The following is a description of a gene set: Cytokines mediate cell-cell communication in the immune system and represent important therapeutic targets. A myriad of studies have highlighted their central role in immune function, yet we lack a global view of the cellular responses of each immune cell type to each cytokine. To address this gap, the authors created the Immune Dictionary, a compendium of single-cell transcriptomic profiles of more than 17 immune cell types in response to each of 86 cytokines (>1,400 cytokine-cell type combinations) in mouse lymph nodes in vivo. A cytokine-centric view of the dictionary revealed that most cytokines induce highly cell-type-specific responses. For example, the inflammatory cytokine interleukin-1β induces distinct gene programmes in almost every cell type. A cell-type-centric view of the dictionary identified more than 66 cytokine-driven cellular polarization states across immune cell types, including previously uncharacterized states such as an interleukin-18-induced polyfunctional natural killer cell state. from publication Cui A, Huang T, Li S, Ma A, Pérez JL, Sander C, Keskin DB, Wu CJ, Fraenkel E, Hacohen N (PMID 38057668) species: Mus musculus Mouse Gene Set: CUI_T_CELL_CD8_IFNB_RESPONSE_UP Genes positively differentially expressed in cell type: CD8+ T cell upon treatment with cytokine: IFN-β in mouse lymph nodes in vivo., and this is the list of marker genes: Ifi213 (NCBI Gene Id 623121), H2-D1, Tmem184b, Herc6, Mitd1, Ifit1bl1, Cpne3, Nlrc5, Smchd1, Uba7, Laptm4a, Plac8, Ms4a6b, Taldo1, Ifi27l2a, Plgrkt, Ms4a6d, Trim25, Ankfy1, Ncl, Tasor2, Trim26, Ifit1, Cnot6l, Icam1, Phip, Nsd3, Il2rg, Vars1, Asb13, Max, Psma3, Lgals9, Ifi208, H2-Q4, Usp18, Lgals8, Aida (axin interactor, dorsalization associated), Ubald2, Tmem192, Gpr18, Mrpl30, Tor3a, Cars1, Slamf7, Stat1, Hk1, Zcchc2, Epsti1, Rgs1, Myd88, Ifi204, Ms4a4b, Trim30d, Bbx, Cd274, Apobec3, Hspa5, Gbp6, Pdcd10, Cmpk2, Isg20, 9930111J21Rik2, Tut4, Clic4, Art2b, Dhx58, Irf2, Slfn1, Ezr, Pdlim2, Sell, Arl6ip1, Lsm4, Bst2, Phgdh, Fchsd2, Cxcl10, Parp14, Tgtp1, Rtp4, Ppp6r1, Etnk1, Jaml, Svbp, Pttg1, Ptma, Keap1, Socs1, Rbck1, Rnf213, Tap2, Mthfd2, Oas1a, Gbp3, Mndal, Tlr7, Sp110, Gbp5, Sp100, Ppa1, Zup1 (zinc finger containing ubiquitin peptidase 1), Med28, Psma4, Ranbp1, Pim1, Oas2, Setdb2, Usp25, Pnpt1, Dtx3l, Clec2d, Plaat3, Shisa5, Ifitm3, Tmem243, Psmb10 (NCBI Gene Id 19171), Ms4a4c, H2-K1, B4galt5, Trim12c, Nup210, Irf8, Atp8a2, Larp1, Calhm6 (NCBI Gene Id 215900), Adar, Fam241a, Tapbp, Psmb8, Hsh2d, Ddx24, Isg15, Slfn8, H2-T23, Snx2, Tapbpl, Tcstv4, Psme1, Sdc3, Shmt2, Helz2, Ddx39b, Phc2, Rbm43, Eomes, Irf9, Igfbp4 (insulin-like growth factor binding protein 4), Slfn2, Psme2, Ifi203, Xaf1, Gadd45g, Ogfr, Selenow (selenoprotein W), Parp12, Cycs (NCBI Gene Id 13063), B2m, Prrc2c, Gzma, Rabepk, Parp9, Slfn5, Tnfsf10, Lgals3bp, Znfx1, Ilrun, Stat2, Gbp4, Ube2l3, Cd2 (CD2 antigen), Ly6e (NCBI Gene Id 17069), Cd47, BC051226, Zbp1, Phf11a, Psma5, Eif2ak2, Eif2s2, Gbp8, Pdia3, Ly6c2, Ly6a, Ccnd2, Mov10, Treml2, Iigp1, Trafd1, Gbp9, Map2k1, Tap1, Ctss, Irf7, Chmp4b, Casp8 (caspase 8), Dpp4, Vcpip1, H2-Q7, Phf11b, Acadl, Trim21, Aldoa, Irgm2, Tbrg1, Morc3, Nars1, Samd9l, Pml, Psmb9, Atp8b4, Gtpbp2 (GTP binding protein 2), Fnbp4, H2-T22 (histocompatibility 2, T region locus 22), Nampt, Oasl2, Desi2, Ifi206, Fam111a, Parp10, Trim30c, Cnp, Gbp2, Ncoa7, Capza2, Ifit3, Rsad2, Srsf3, Tcof1, Cd86, Rigi, Irgm1, Cytip, Itpr1, Psma7, Itm2b, Ifi47, Ccrl2, Parp11, Trim34a, Cd53 (NCBI Gene Id 99593), Nmi, Cd69, Ifit2, Ttc39b, Igtp, Samhd1, St6galnac4, Trim12a, Tgtp2, N4bp1, Arf4, Dbnl, Mx1, Srsf7, Psma2, Slco3a1, Rnf114, Ddit3, Ascc3, Dusp28, Tspo (translocator protein), Phf11c (PHD finger protein 11C), Mvb12a, Pgd, Psme2b, Plscr3, Slc25a22, Ifih1, Rbl1, Mycbp2, H2-M3, Tor1aip1, Etv6, Tmbim6, Gng2, Irf1 (interferon regulatory factor 1), Ifi35, Socs3, Ddx60, Tnfsf8, Daxx, Rfc3, Ube2l6, Ifi209, Ogfrl1, Ifi214, Trim30a, Tor1aip2, Snrpd1, Sp140, Stat3, Tbc1d1, Ifit3b, Naa20, Trim56, Gpr65, Msn, Pcgf5, Gbp7, Nes, Oas3, Ifi44, Oasl1, Eif5a, Mbnl1, Wdr43